The following is a description of a gene set: studied in species Homo sapiens Any structural abnormality of the cerebral cortex. Abnormal cerebral cortex morphology Human Gene Set: HP_ABNORMAL_CEREBRAL_CORTEX_MORPHOLOGY, and this is the list of marker genes: TERT, ATXN2, RFC2, ARL3, C2CD3, XRCC4, FKTN, KAT5, FGF8, COL25A1 (collagen type XXV alpha 1 chain), TUFM, EML1, ATP13A2, ERCC3, TUBA8, KATNB1, ERCC5, ZNF526, SCN1B, ACY1, NPRL3, POLG2, TBCD (NCBI Gene Id 6904), GOLGA2, PEX12, IKBKG, H3-3A, DHCR7, EMX2 (NCBI Gene Id 2018), PEX10, SMC1A (structural maintenance of chromosomes 1A), CLCN4 (chloride voltage-gated channel 4), NDUFA8, SCO2, SEPSECS, SCN1A, VPS37D, CIB2, SUFU, RFT1, RAD21 (NCBI Gene Id 5885), PSAT1, DDX3X, AP4M1, CSPP1, PARS2, NEDD4L, TMEM147, STX1B, GLYCTK, GUF1, DDB2, SMC3, CPLX1 (NCBI Gene Id 10815), SPOP, KLHL15, TRAK1, PYCR2, PLK4, NDP, UGP2, HCN1, SLC39A4, PEX26, RNF125, PPFIBP1, GNPTAB, EHMT1, TCF4, SMARCD1, PIGL, KIF21A, DYRK1A, VPS37A, SMO, MT-CO1, PHGDH (phosphoglycerate dehydrogenase), GABRD, MT-ND5, CEP41, POMK, MT-ND6, WDR62, TRAPPC10, CTU2, MARS2, TARS1, TWNK, EPG5, GRIA3, RNU4-2, NUP133, EXOSC5, SYNJ1, TRRAP, RARS2, LAMA2, GTF2E2, LIMK1, RELN, HSPG2, MN1, DAG1, SNF8, TMEM70, PDHB, KDM6A, CNKSR2, MKS1, CDC40, NIPA1, FDXR, CDKL5, MICU1, ELOVL4, TSC2, DPM1, SARS1, SUZ12, CAMTA1, GON7, TP53RK, FKRP, MTRR, TRAPPC9, GNB1, CDK13, BLTP1, SNAP29, MAN2B1, NIPA2 (NCBI Gene Id 96367), PEX19, ACTB, GLS, ERCC2, KATNIP, VPS13A (NCBI Gene Id 23230), TMX2 (thioredoxin related transmembrane protein 2), IFNG, ITPR1, KIAA0586, FOXH1, KMT2D, MT-ND4, GABRG2, ATP5F1A, SLC35C1, ATP6V1E1, CHCHD10, KCNA1, NSDHL, LMNB2, COPB2, ATP6V1B2, RTTN, RPGRIP1L, MTOR, MT-TH, SRPX2, GRIA4, METTL27, NUS1, CSNK2A1, MBTPS2, PIK3CA, FIG4, ETFDH, SLC25A19, PLP1, LRPPRC, NOVA2, PEX16, SCN9A, MAN2C1, NODAL, GNAO1, CWC27, PDE6D, MECP2, ARMC9, TMEM237, VPS13C (NCBI Gene Id 57581), SCN2A (NCBI Gene Id 94312), PIGB, PI4KA (phosphatidylinositol 4-kinase alpha), TCTN1, ACTG1, KIF11, RAC1, AP1S2, RPS6KA3, NEUROD2, ASNS, PIGA, SMARCE1, PDHA1, CTDP1, UBE3A, AKT3, SCN3A, CYB5R3, APC2, WDR4, MED27, CDK5RAP2, RAB3GAP1, HIC1, DNAJC30, ARHGAP31, PEX14, DEPDC5, SF3B4, ZNHIT3, TUBB, PEX11B, POMT1, NPRL2, INTS11, PIGQ, PEX6, AHDC1, CEP295, FBXO28, ARL13B, ERCC4, ARX, CENPJ, TMEM222, CRPPA, USH1C, ETFA, RTL1, OSGEP, IFT74, OPHN1, SIX3, FMR1, ACD, ASCC1 (activating signal cointegrator 1 complex subunit 1), MMACHC, POLR3B, MFSD2A, VPS35, FA2H, ERMARD, NCF1, GRIN1, ZNF335, KIAA0753, COL18A1, RXYLT1, XPC, WWOX, TBR1, SETBP1, MAP1B, YY1, TBC1D24, ATP5MK, TSC1, RNU12 (NCBI Gene Id 574043), B4GAT1, EIF4H, NDN, ATRX, INPP5E, OFD1 (NCBI Gene Id 8481), AP4E1, PPIL1 (NCBI Gene Id 5482), ATP6V0A2, PGAP1, DMXL2, GBA2, KDM5A, MBOAT7, COG6, PTDSS1, CNNM2, AXIN1, LAMC3, MT-TQ, TRAIP (NCBI Gene Id 10293), GIGYF2, GPX4, ADARB1, DYNC1H1, PDCD6IP, CPA6, PUS3, SIK1, SKI, GNAQ, TMCO1, PPP1R12A, PIGS, RNF113A, SMARCC2, SLC32A1, ACO2, VRK1, ATP6V0A1, CLP1, POMGNT1, TRIM8, ARHGEF9, ISCA1, TUBG1, FKBP6, EIF4G1, TMTC3, MUC1, WDR73, MLYCD, PAX6, TTC19, SIN3A, CNTNAP2, ATPAF2, POMT2, APP, CILK1, TMEM67, MMADHC, MAPK8IP3, FOXG1, EXOSC3, TRMT10C, HEXB, ADA2, WFS1, MEG3, BRD4, LARGE1, FRMPD4, EXOC7, ATN1, DISP1, CUL4B (NCBI Gene Id 8450), MT-ATP8, COL4A2, DNAJC13, ATP5F1D, ANKLE2, SLITRK2, KNL1, LIPT2, DOCK7, TUBGCP6, GABRA5, ALS2, RHOBTB2, CASZ1, EXOSC2, AFG2A, SIN3B, CBY1, STAMBP, PEX5, TSEN34, MEF2C, VAC14, TMEM218, MT-TF, BMP4, ETFB, BAZ1B, MAGEL2, LRRK2, GPSM2 (G protein signaling modulator 2), DLL1, PIGV, BRAF, SPG11, NAA60, MPLKIP, CENPE, PNKP, SORL1, COL3A1, PEX7, FGFR3, MT-TS2, FRMD5, SNCA, BUB1, FARS2 (NCBI Gene Id 10667), STX1A, ADGRV1, MBD5, NPHP1, VIPAS39, CLIP2, SASS6, DLK1, ZEB2, ERCC1, TOGARAM1, TAF13, DGUOK, LAMB1, PCDH15, TPRKB, TYROBP, MAST1, SNX14, EOMES, IBA57, TBC1D20, WHRN, TSEN54, USP18, ATP1A3, CASK, TMEM106B, SLC9A6, EIF2B4, TCTN2, PIGN, FGF13, KIF2A, PC, TMEM270, POLR3A, NUP37, MYCN, MT-ATP6, MAP2K1, POU4F1, SLC12A2, GBA1, RRAGC, PSEN2, SMPD4, CHMP2B, JPH3, CCBE1, STS, VPS4A, CEP120, ALG8, SPTAN1, CPT2, ZSWIM6, NDE1, TOMM40, SON, PCDHGC4, PEX1, PTCH1, PRDM16, AARS1, SMARCB1, AGTPBP1, RAB3GAP2, SLC25A46, TUBA1A, SLC5A6, PEX2, MT-TL1, SLC35A2, FAT4, KIF26A, FUS, IER3IP1, SQSTM1, PPP2R2B, BICD2, ATP8A2, CDK6, ADAMTS3, HIVEP2, GRN, HSD17B4, HRAS, NARS1, BUD23, LAGE3, KAT6B, PSEN1, MED11, CDH23, TUBB3, KIF14, GET4 (NCBI Gene Id 51608), CEP152, TBL2, ACTA2, OCA2, GFM2, SPG7, HDAC8, EXOSC9, CCDC88A, MYO5A, GMNN (NCBI Gene Id 51053), RECQL4, ROBO1, MCPH1, TREM2, TBL1XR1, UBE4B, TCTN3, CDC42, MCM7, LUZP1, KIF5C (kinesin family member 5C), SHMT2, CDON, RNU4ATAC (RNA, U4atac small nuclear), FBLN1 (NCBI Gene Id 2192), TUBGCP2, PIDD1 (p53-induced death domain protein 1), PAFAH1B1, CRIPTO, WDR26, GCDH, ODC1, GRM7, SLC30A9, GTF2IRD1, TARDBP (NCBI Gene Id 81927), TSEN2, STUB1, PEX3, TP73, PRUNE1, TUBGCP4, TBK1, SLC25A15, ZIC2, ATP5F1E, XPA, FH, WT1, TRAPPC6B, DOCK6, TTC5, TINF2, EXOSC8, OCLN, DONSON, MDH2, MMP23B, SRD5A3, MT-CO2, FLVCR2, UBTF, SNRPN, EIF2AK2, GAS1, USP9X, POMGNT2, WBP4, SLC39A8 (solute carrier family 39 member 8), TSEN15, PANK2, DPAGT1, SCYL2, B4GALNT1, PIK3R2, FTO, MAF (NCBI Gene Id 4094), PDZD7, CDK5, PRDX1, TRAPPC12, MACF1, PHOX2A, ARID2, BICRA, CLN5, RMND1, NCAPD3, QARS1, CACNA1E, STIL, CPLANE1, DKC1, B9D1, HNF1B, FDFT1, VPS33B, ADGRG1, USH2A, VLDLR, NFIX (nuclear factor I X), FLI1, ATR, TUBB2A, BMPER (BMP binding endothelial regulator), MT-TW, GMPPB, NEXMIF (NCBI Gene Id 340533), NSRP1, CIZ1, NEK1, SOX11, CARS1, METTL5, PDPN, YWHAE, MVK, CTNNA2, MAP2K2, PRNP, PIBF1, MT-CO3, ARID1A, COL4A1, POGZ, NUP107, SPEN, ELN, MYO7A, RTEL1, VCP (NCBI Gene Id 94731), PLAA, ATP6V1A, DCX, AP4S1, ASPM, CISD2, B9D2, TAF6 (NCBI Gene Id 6878), PHACTR1, HERC1, HYLS1, ALG12, CCND2, RNASEH1, PIGP, CACNA1A, DHCR24, LONP1, DCHS1, CASP2, CAMSAP1, SHH, AHI1, CYB5A, MPDZ, CEP63, CRADD, ALDH18A1, DYNC1I2, B3GALNT2, HSD17B10, PHC1, PTEN, ABCA7, YRDC, CTSF, GTF2IRD2, BCAP31, FRAS1, ESAM, NDUFA6, MAPT, MT-ND1, DPF2, MINPP1, B3GLCT, KCNAB2, GTF2I, PRKDC, ESPN, VARS1, NIPBL, NANS, WARS1, TRAPPC14, CEP135, ERCC6, ATP1A2, RERE, PRRT2, SMARCA4, GPHN, GPKOW, KIFBP, SLC25A22, AMPD2, ARID1B, CEP85L, APOE, KRAS, COG1, PRKCZ, CARS2, SOX4, TUBB2B, OTUD6B, AP4B1 (NCBI Gene Id 10717), GDAP2, SHQ1 (NCBI Gene Id 55164), CEP104, IARS2, TGIF1, FBXL4, DHX37, LMNB1, KCNT1 (potassium sodium-activated channel subfamily T member 1), FGFR1, PEX13, GLI2, CIT, SACS, PARN, GTF2H5, USH1G, RAB18